The following is a description of a gene set: from publication Kang HS, Kim YS, ZeRuth G, Beak JY, Gerrish K, Kilic G, Sosa-Pineda B, Jensen J, Pierreux CE, Lemaigre FP, Foley J, Jetten AM (PMID 19805515) Genes downregulated in the postnatal day 3 pancreata with impaired function of GLIS3. Mouse Gene Set: KANG_GLIS3_TARGETS Chromatin assembly factor 1 (CAF-1) deposits histones H3 and H4 rapidly behind replication forks through an interaction with the proliferating cell nuclear antigen (PCNA), a DNA polymerase processivity factor that also binds to a number of replication enzymes and other proteins that act on nascent DNA. The mechanisms that enable CAF-1 and other PCNA-binding proteins to function harmoniously at the replication fork are poorly understood. Here we report that the large subunit of human CAF-1 (p150) contains two distinct PCNA interaction peptides (PIPs). The N-terminal PIP binds strongly to PCNA in vitro but, surprisingly, is dispensable for nucleosome assembly and only makes a modest contribution to targeting p150 to DNA replication foci in vivo. In contrast, the internal PIP (PIP2) lacks one of the highly conserved residues of canonical PIPs and binds weakly to PCNA. Surprisingly, PIP2 is essential for nucleosome assembly during DNA replication in vitro and plays a major role in targeting p150 to sites of DNA replication. Unlike canonical PIPs, such as that of p21, the two p150 PIPs are capable of preferentially inhibiting nucleosome assembly, rather than DNA synthesis, suggesting that intrinsic features of these peptides are part of the mechanism that enables CAF-1 to function behind replication forks without interfering with other PCNA-mediated processes. studied in species Mus musculus, and this is the list of marker genes: Ldlr, Ins1, Frzb, Ins2, Vdr, Pax4, Slc2a2, Sytl4, Foxj1, Sst (NCBI Gene Id 20604), Pyy, Abcc8, Isl1, Neurog3, Cltrn, Iapp (islet amyloid polypeptide), Neurod1, Ppy, Pax6, Ghrl, Ppp1r1a, Pcsk2, Nkx6-1, Scg5, Mafb, Psmb10, G6pc2, Rbp4, Rims3, Gcg, Slc2a5, Gjd2, Chga, Scgn, Syt13, Srp9, Ctrl (NCBI Gene Id 94036)